Given this list of marker genes CKS2, RPS27, MLLT3, BZW2, UROD, LAPTM4B, ETV5, C1QBP, TFR2 (NCBI Gene Id 7036), NUDT4, ARHGEF12, HMGB3, PHYH, RPS6, TAX1BP3, PIP5K1B, GRK5, CXCR4, PCIF1, KHDRBS3, RAB38, HSPB1, IL1B, TMEM45A, CRYGD, TNFSF10, BEX1, NDN, MECOM, MAL, ICAM2 (NCBI Gene Id 3384), ACTR2, RPL35, ATP1B1, NPR3, CFH, LSM5, PSEN2, SRGN, KLHL7, PRDX2, LEPROT, AKR7A2, ELF1, SHMT2, MAFF, TMEM14A, RGS2, PLS3, RPS27L, METTL9, TXNIP (NCBI Gene Id 10628), CEBPB, TMEM258, ALDH6A1, ICAM4, SLC39A8, TIMM13, KLF2, LIMCH1, CTDSPL, COX7A2L, FHL2, RPL36A, CAT, TJP2, TCF25, RALBP1, SERPINE2 (NCBI Gene Id 5270), GADD45A, TNS1 (NCBI Gene Id 7145), ACTN1, HSP90B1, DLK1, OXT, GABARAPL1, PTPN11, PMAIP1, OGFOD3, SUCLG2, NFIB, BST2, S100A6, TAL1, IFI16, HSPA1A, FAM124B, MARCKS, here is a description of the gene set: Human Gene Set: HOEBEKE_LYMPHOID_STEM_CELL_DN species: Homo sapiens from publication Hoebeke I, De Smedt M, Stolz F, Pike-Overzet K, Staal FJ, Plum J, Leclercq G (PMID 17170726) Hematopoietic stem cells in the bone marrow (BM) give rise to all blood cells. According to the classic model of hematopoiesis, the differentiation paths leading to the myeloid and lymphoid lineages segregate early. A candidate 'common lymphoid progenitor' (CLP) has been isolated from CD34(+)CD38(-) human cord blood cells based on CD7 expression. Here, we confirm the B- and NK-differentiation potential of CD34(+)CD38(-)CD7(+) cells and show in addition that this population has strong capacity to differentiate into T cells. As CD34(+)CD38(-)CD7(+) cells are virtually devoid of myeloid differentiation potential, these cells represent true CLPs. To unravel the molecular mechanisms underlying lymphoid commitment, we performed genome-wide gene expression profiling on sorted CD34(+)CD38(-)CD7(+) and CD34(+)CD38(-)CD7(-) cells. Interestingly, lymphoid-affiliated genes were mainly upregulated in the CD7(+) population, while myeloid-specific genes were downregulated. This supports the hypothesis that lineage commitment is accompanied by the shutdown of inappropriate gene expression and the upregulation of lineage-specific genes. In addition, we identified several highly expressed genes that have not been described in hematopoiesis before. Genes down-regulated in the common lymphoid progenitor (CLP, defined as CD34+CD38-CD7+) compared to a multipotent cord blood cell (defined as CD34+CD38+CD7-).